Given this list of marker genes UQCC2, DDX5, CYP26B1, DDX17, S100B, MIR1-1, MEF2C, EPHB1, BMAL1, TBX1, RBM24, MSTN, KLHL41, SIX1, MYOCD, MCUB, NR1D2, SIX4, GPC1, KAT8, NLN, SIRT2, AKIRIN1, here is a description of the gene set: Human Gene Set: GOBP_REGULATION_OF_SKELETAL_MUSCLE_CELL_DIFFERENTIATION species: Homo sapiens Any process that modulates the frequency, rate or extent of skeletal muscle cell differentiation.